The following is a description of a gene set: studied in species Mus musculus electronically inferred by orthology from the curated human pathway Reactome Pathway: Elastic fibre formation This event has been computationally inferred from an event that has been demonstrated in another species.<p>The inference is based on the homology mapping from PANTHER. Briefly, reactions for which all involved PhysicalEntities (in input, output and catalyst) have a mapped orthologue/paralogue (for complexes at least 75% of components must have a mapping) are inferred to the other species. part of: Extracellular matrix organization, and this is the list of marker genes: Mfap2, Mfap5, Bmp4 (NCBI Gene Id 12159), Ltbp3, Vtn, Itgb8, Loxl1, Loxl2, Bmp10, Loxl3, Tgfb1, Loxl4, Fbln5, Mfap4, Bmp7, Lox, Ltbp2 (NCBI Gene Id 16997), Emilin2, Itgb5, Itga5